Given this list of marker genes PRMT6, AFG3L2, DLD, PGK1 (phosphoglycerate kinase 1), SPCS1, CTSC, ADAMTS18, TIMP2, ASTL, ADAM2, METAP1, RBBP6, PABPN1L, ZYG11B (NCBI Gene Id 79699), KLK8, PTPN23, CELA3A, KLHL12, PRAMEF7, RNF148, KLHL42, HGS, ECSCR, PCYOX1L, USP19 (ubiquitin specific peptidase 19), USP17L11, KLHL22, CHMP2B, HINT1, TLL2, MINDY1, UFSP1, ELANE, CDC16, JMJD7, PRSS58, AMBRA1, NRIP3, SENP8, SDE2, MAGEA3, VPS36, AFG2B, UBXN6, RCHY1, ADAMDEC1, CDC27, ANKZF1, PSMB7, RC3H2, KLHDC1, PGPEP1L, CAPN11, LRRC75A, NEDD8, OPHN1, PKD1, CSTB, PTPN1, OTUD3, MAGEF1, APH1A, PGA5, GSN, CTSV, MEP1A, HIPK2, DTL, TANK (NCBI Gene Id 10010), SIAH3, AURKAIP1, UMOD, PRAMEF5, PRSS41, SIRT2, TF, PSMF1, UQCRC2, DESI1, USP18, WDR26, LONRF2, PHEX, KLHL28, PLGRKT, CPD, USP20, NFE2L2, PRPF19, FADD, CAPN13, SNF8, RSPRY1, EFNA1, CHMP1B, CASP3, MVB12A, PGA4, MAEA, CFL1, SNX33, GID8, ENC1, CDC23, FEM1B, TMUB2, ANAPC11, MPND, UBXN8, CAPN5, SOCS2, ANAPC10, TMPRSS11A, PRAMEF8, SEC61B, DCST1, STAM2, DNAJC3, DYNC2H1, CPLANE2, ASB9, CASP8, PRAMEF11, CIROP, PEPD, PRICKLE1, VHL, UBR3, CDC26, PSMA6, RNF139, ANAPC2, MTOR, GAS1, UBE2U, PRAMEF6 (PRAME family member 6), GIPC1, PSMD12, COMMD1, CBFA2T3, BAG5, FBXO22, MMP15, COPS5, PRNP, SGTA, DDI1 (DNA damage inducible 1 homolog 1), VTN, CANX, PRSS48, FAP, NTAN1, CBL, CAPN3, ANAPC13, RNF7, RNF168, USP6, SUMO2, MYSM1, IMMP1L, C1S, SPG7, UBC, RFPL1, UBXN2B, PSME3IP1, NHLRC1, MBP, DDRGK1, RCE1, BMP1, OTUD7B, CHMP1A, PTK2B, PCSK2, GAN, TNFRSF1B, SPPL2B, OVCH2 (NCBI Gene Id 341277), PRAMEF26, MMP10, PRAMEF1, UBE2L6 (NCBI Gene Id 9246), FGB, TGM2, VSIR, SPOCK2, USP46, UBA6, ATP5IF1, ADAMTS10, CPA5, CLU, MYLIP (myosin regulatory light chain interacting protein), RPL23, AGBL4, MINDY4, MINDY2, SERPINB4, RBMX, RNF19B, ACTMAP, ITCH, TAF9, PARL, OXA1L, RPL11, USPL1, SPSB3, PRSS33, HERC4, UBE2S, RNF20, DPEP3, RNF11, GPX1, MYH9, ARIH1 (NCBI Gene Id 25820), MMP1, KLHL2, KCNE2, ADAM33, ANKRD9, ADAMTS1, RAD23B, UBE2D2, TRAF4, RNF180, ASCC2, UBE2C, AGTPBP1, ERMP1, MMP28, USP17L22, USP34, PRAMEF20, CARD18, FBXL19, ISG15, NSFL1C, TP53INP2, CHMP2A, CELA2A, MMP17, TRIM58, MYC, RNPEP (NCBI Gene Id 6051), NHLRC3, USP43, PCSK1N, MARCHF7, DNAJB9, TOLLIP, SLC30A8, PSMC2, PDCD6IP, CDK5RAP3, PSMA2, GGT3P, RPGR, UBQLN4, SHH, PIGK, KLHL20, PSMB4, COPS3, MST1L, PITRM1, PROC, HECW1, HERPUD1, SNX12, RMND5B, ATP6AP2, CSNK1D, FBXO10, ECRG4, VCPIP1, PSMD3, DPEP1, EPPIN, RHBDD2, UCHL1, ADAM30, PRAMEF25, FXN, PML, NFE2L1, UBXN4, TRIB3, TBL1X, TMTC3, SERPINE2, UBA52 (NCBI Gene Id 7311), FBXO6, KAT5, USP17L20, SERPINB3, ADAMTS2 (ADAM metallopeptidase with thrombospondin type 1 motif 2), HSP90B1, SCRN3, OS9, ANAPC16, ERLIN2, PSMB11, ANAPC5, GGT1, TOR1A (NCBI Gene Id 1861), VASH2, USP15, SPRTN, UBE2I, PPP2CB, ZFAND2B, RNF126, DCAF13, CRB2, JOSD2, ZMPSTE24, USP12, USP17L13, KCTD2, USP26, OTUB1, ADAM18, FBXL15, ALAD, UBE2W, FKRP, TIMP3, TRIM45, UBXN1, FBXO31, SERPINE1, GSAP, FBXO3, ELOB, KLK7, TMEM208, TNFAIP3 (TNF alpha induced protein 3), ADAM9, RNF40, DNAJB2, ADAMTS4, LIAT1, FBXO38, FBXO44, ADAM21, FBXO4, MMP21, KLHL1 (NCBI Gene Id 57626), BLMH, PRSS42P, OTUD6B, PRAMEF17, PRAMEF12, KLK6, RHOBTB3, SMURF1, TMEM129, HERC3, TMPRSS13, EIF3F, SIRT1, FBXL2, ACE, MAN1A1, MATCAP2, PRSS29P, KLHL17, SERPINB8, ARHGAP5-AS1, GRN, COLEC10, SERPINB9, LNPEP, CSNK2A1, PRELID1, DERL3, ZNRF4, PREP (prolyl endopeptidase), FBXW4, MME, UBE2K, CFB, USP17L15 (NCBI Gene Id 124906420), HPR, FBXL20, PCSK1, SDF2L1 (stromal cell derived factor 2 like 1), UBR1, DPP7, ERO1B, ADAMTS15, PRSS51, SUMO1, CNOT4, OMA1, AGBL3, FBXL3, FBXL7, AGA, HECW2 (HECT, C2 and WW domain containing E3 ubiquitin protein ligase 2), STUB1, RNF128, PIDD1, MMP12, ESPL1, CLCA4, TSPAN15, ADAM22, CTSG, TRHDE, PTK2, UBQLN2, WDR77, CLPP, MMP7 (matrix metallopeptidase 7), PSMA3, ACR, TRAF3, TMEM259, MMP25, USP49, TINAG, USP14, F2, CUL2, USP17L18, APOH, BRSK2, IL10, OTUB2, RHBDD1, STAMBPL1, PPP1R11, USP7, FBXL18, DPEP2 (NCBI Gene Id 64174), DPP6, HGFAC, OTUD5 (NCBI Gene Id 55593), USP31, GGT2P, ADAMTS13, PRSS12, BAG6, TPP1, DHCR24, PREPL, SEC11C, TMPRSS4, GZMB, CHMP6, ADAM29, CRBN, AMN1, ATG4B, TNF, RELN, RET, PGPEP1, CELA1, DERL2, ALG13, CHMP5, USP40 (ubiquitin specific peptidase 40), HTRA1, PSMD11, TMPRSS9, KLF1 (NCBI Gene Id 8055), CARD17P, PRAMEF27, MEP1B, PRAMEF22, GID4, PRSS8, PCYOX1, KCTD17, CCAR2, ENDOU, ADAM15, ATXN3, NCSTN, TMPRSS3, TMPRSS11D, MMP26, RNF122, UBE4A, ARIH2, ADAMTS14, METAP2, APEH, ADAM10, GLI3, AXIN1, PRAMEF14, NRDC, ASB1, PSMD1, SPOCK3, UBAC2, CSTL1, FBXO21, PSME2, RHBDF1 (NCBI Gene Id 64733), DNPEP, ATXN3L, TRIB2, APPBP2, BACE2 (NCBI Gene Id 25825), MBTPS2, CDK5, MAN1B1, VASH1, CCNF, USP22 (NCBI Gene Id 79397), KLHL15, MIDN, TRIM67, HGF, USP51, TPSB2, CPA3, ERLIN1, CAPN9, PRKACB, TRIP4, PM20D1, DPP3, RNF111, BAD, CHMP4B (NCBI Gene Id 60501), CLN6, COMP, CPA4, CTSK, KLK12, PRAMEF19, MELTF, UBE2D3, PISD, FBXL22 (F-box and leucine rich repeat protein 22), TBL1XR1, MAN1A2, HDAC6, SPCS2, ADAM7, PRSS3P2, RNFT1, KLHL29, UBE2B, USP17L2, CTSH, EEF1AKMT4-ECE2 (EEF1AKMT4-ECE2 readthrough), CAPN12, SH3RF3, LONP1, NPLOC4, MMP14, USP54, HPN, ECM1, DPP4 (NCBI Gene Id 1803), IFNG, ADAM12, DESI2, ADAMTS9 (NCBI Gene Id 56999), PRAME, BFAR, NDFIP2, FBXL6, SEL1L, NR1H3 (nuclear receptor subfamily 1 group H member 3), TPSG1, UBE2L5, CPQ, XPO1, PTPN3, CHMP7, CNTN2, IDE, USP9X, DCAF11, KLK11, KLHL6 (kelch like family member 6), FBXW7, ACAN, ATP23, IFT52, VPS37B, KCMF1, CTSL, CPA6, GLMN, ANXA2, HFE, TNP2, PSMC1, IL1B, SERPINB1, LMLN, KEAP1, ENO1, MYRFL, CTSB, RNF115, C1R, NAALAD2, RNF125, KNG1, TGFB1, UBE2E1, UBQLN1, WFS1, SENP3, DPP9, PAQR3, PSMD10, ZNF598, CST3, PGA3, SPSB2, ACE2, CUL4A (cullin 4A), BCHE, UBAP1, TRIM71, RAD23A, TMPRSS11B, MALT1, CLGN, PRSS21, SEC11A, CCIN, SKP2 (S-phase kinase associated protein 2), PYHIN1, CDC20B, C2, KLK14, PRSS3, FOXRED2, SH3RF2, DNAJB12, RNF26, TMEM67, IMMP2L, RHBDL1, CPB1, KLKB1, F7, SPPL3, ECE2, CHMP4A, COLEC11, PSMA8, WDR91, F9, USP9Y, PCNP, ECEL1, MMP8, FBXO46, MMEL1, ASCC3, FGFR4, SPON1, PLAU, PSMD14, STT3B, UBE2A, USP30, APH1B, MMP9, BIRC2, TRIP12, KLHL38, CTSO, CNDP2, FAM8A1, USP11, PCBP2, RBX1, F10, OSBPL7, KLK13, RNF121, MIB1, TIMP1, RNF14, CASP5, PLK3, CAV3, TRIM28, DPP8, NEMF, UBXN11, FEM1A, PEX10, IPP, CASP14, TRIM38 (tripartite motif containing 38), PTEN, MAFB, ADAM17, PRSS55, REN, APC2, IST1, AGBL5, TSG101, S100A10, KLK15, PLK1, CAPN8, PROZ, PLA2G7, KLK4, SPSB4, KLHL41, RCN3, USP5, RFX4, TRIM31, LACTB (lactamase beta), RNF144A, PCSK4, SENP2 (SUMO specific peptidase 2), FAU, ADAM32, PRSS36, ADAMTS7, PCSK6, CALR, SPPL2C, RNF133, UBA1, CUL1, IFI27, TRIM72, RNF185, HDAC2, MKRN2, FBXL13, NEDD4, PAPPA, PRSS16, UBE2R2, XBP1, PTCH1, MIR126, FAF1, KLHL24, AMZ2, HTRA2, LRRK2, WNT10B, TPSD1, RNF130, SENP5, PACSIN3, PSMA1, SMURF2, SERPINF2, TMPRSS12, F3, MASP1, PSME4, CAPNS1, YOD1, CAPN15, RBP3, CPXM2, TMPRSS15, EDEM3, MMP20, FGG, HACE1, PCSK5, CLOCK, DTX4, XPNPEP1, ZFAND2A, SEMG2, NAGLU, YIPF5, PRAMEF4, CLPX, BCAP31, UBR2, TAF1, AKIRIN2, PDCL3, LONP2, UBE2D1, USP3, CLEC3B, WWP2, RPL5, UBAP1L, EIF3H, ERCC8, VPS37C, RNF19A, ZER1, PMPCA, TRIM32, SH3D19, MIR152, NKD2, RYBP (RING1 and YY1 binding protein), UBR4, GGT5, MTM1, ASPH, ASB2, DCAF12, PSMB1, FOLH1B, PSMD4, AGAP3, WDR81, DDIT3, ACP4, CASP6, A2ML1, CUL3, PLAUR (plasminogen activator, urokinase receptor), UBE2Z, HTRA4, SIAH2, SVIP, CDC34, FBXL16, RNF6, FAM111A, RNF103, USP21, SRC, PRSS27, KLHL3, PRAMEF9, CPVL (carboxypeptidase vitellogenic like), TMUB1, KLHL30, FZR1, TMPRSS11F, ATG4D, UBA7, FAM111B, ST14, PSEN1 (NCBI Gene Id 5663), SUFU, MTA1, TRIM39, IHH, PSMD13, SH3RF1, HABP2, OVCH1, WAC, TMPRSS6, DET1, CLN3, FBXW5, CAPN7, USP36 (NCBI Gene Id 80160), UBR7, CFD, PRAMEF15, CSNK2B, SOCS7, STAMBP, PSMC6, RUNX1, ADAM11, SOCS4, CPA1, CHAC1, DAB2IP, ATP13A2, RGMA, VPS25, F8A3, GLG1, KLHL7 (NCBI Gene Id 55975), PRSS22, SPPL2A, PRSS50, TMF1, UBXN7, SYVN1, UFD1, STYX, PM20D2, PRAMEF2, RFFL, PGC, RNF25, UBE2J2, ECE1, NR1H2, USP37, CTSD, FBXO17, PRSS53, GZMA, CDK2, L3MBTL3, SEMG1, TNP1, NPEPPS, DCD, RPS6KA2, CYFIP2, KBTBD7, CST4, MARCHF6, TRABD2A, CAPN14, PRSS38, SAYSD1, KEL, YME1L1, TMPRSS11E, LAMP3, CASP10, CDKN2A, RNF149, USP25, RNF5, CASP1, SNX9, PSEN2, PITHD1, KLHL8 (NCBI Gene Id 57563), CAV1, HUWE1, AURKA, OTULIN, SEM1, ARMC8, TRPC4AP, RECK, USP4, NCCRP1, RPS7, ZNRF1, VPS4A, ADAM19, CWH43, CPN1, TSPAN17, MMP27, TREM2, C1RL, H2BC1, USP17L1, CPB2, CELA2B, MMP11, CR1, CHMP4BP1, CTRB1, NUP98, DHH, DDA1, THOP1 (thimet oligopeptidase 1), TNFAIP1, CTSA, AQP11, CCBE1, FBXO7, FBXL14, PRAMEF13, UBE4B, PSMB10, PABIR1, PRSS45P, KDM8, KLK2, TOM1L1, THBD, XPNPEP2, AXIN2, PCSK7, VPS4B, KLHL18, IVNS1ABP, TMPRSS5, XPNPEP3, NEURL3, SCG5, NAPSA (NCBI Gene Id 9476), PHF20L1, CAPN10, KLK10, RNF123, ADRM1, KCTD6, PIK3C3, EPHA4, SVBP, TMPRSS2, CAPN6, APP, SIRT4, TRABD2B, NPEPL1, ADAMTS20, ZNF418 (zinc finger protein 418), ADAM8, ADAMTS17, KLHDC3, ANAPC1, SRGN, VPS37A, MAN1C1, PRTN3, VPS28 (NCBI Gene Id 51160), NRIP2, HSPA5, RNF8, CELA3B, PELI1, USP28, USP2, CFH, TIMP4, STOML2, KLHL23, SENP6 (SUMO specific peptidase 6), UCHL3, UBE3A, KLK1, USP17L10 (ubiquitin specific peptidase 17 like family member 10), KLHL10, TRIM2 (tripartite motif containing 2), CHFR, UBE2G1, CORIN, RPS27A, USP47, FBXL12, PIP, SCRN1 (NCBI Gene Id 9805), MIR128-1, UBE3B, CFLAR, DNAAF4, ADAMTS12 (NCBI Gene Id 81792), CTSF, TYSND1, AUP1, PRSS47P, PSMA5, TBC1D10A, ATG4C, WNT1, ELOC, LTN1, MVB12B, ADAMTS3, MYRF, PRSS23, ANKIB1, RACK1, CASP12, PSMB9, GSK3A, CASP9, ENPEP, TRIM26, COP1, RNF215, EDEM2 (ER degradation enhancing alpha-mannosidase like protein 2), CLN8, INPP5B, RC3H1, CSNK1A1, HERC6, JKAMP, PLAT, PEX12, ANAPC15, SHARPIN, UBL7, LAP3, SMARCC1, PSMD6, SENP7, N4BP1, HJV, GZMK, RNF34, BRCC3, SQSTM1, ERAP2, PSMD9, EPM2A, HM13, OTUD6A, CEBPA, FHIT, FCN2, DISP1, NPEPPSP1, CBLC, RNF10, FBXO11, SERPINB13, CMA1, RNF4, KCTD10, RNF43, PSENEN, PSMA4, UBXN2A, TMX1, SCRN2, RNF41, PSMC4, SENP1, RNF216, CTSS, LDLRAD3, FBXW2, UBA3, SPCS3, PMAIP1, RNF13, TMEM168, CTSE, PRSS57, ANPEP, TRIM21, CTRB2, F12, HSPA1B, USP17L6P, LCN1, MAPK9, RNF186, PSMD7, UBXN10, BRINP1, VPS37D, SPOP, NDFIP1, TOPORS, AZU1, IFT172, PBK, FBXO9 (NCBI Gene Id 26268), UBE2N, UBB, CACUL1, AKT1 (AKT serine/threonine kinase 1), PAPPA2, PSMB3, FOLH1, FBXO8, UFL1, TGFB1I1 (NCBI Gene Id 94988), GPLD1, UFSP2, FOXF2, QRICH2, TINAGL1, ADAM20, ROCK1, PANO1, MINDY3, DDB1, HID1, KLHL35, UBD (NCBI Gene Id 95374), PRAMEF33, KCTD21, NEDD4L, FBXW8, RNF170, FBXO27, TLL1, ARRB1, GNA12, GET4, PSMB6, CPM, BAP1, UCHL5, RHBDL3, CUL7, GCLC, KLK9, HSPA1A, FURIN, TRIM3 (tripartite motif containing 3), PINK1, DVL1, GAPDH, GABARAP, USP35, NUDT15, RNF217, TSPAN5, FGA, FBXW11, ADAMTS19 (ADAM metallopeptidase with thrombospondin type 1 motif 19), KBTBD12, DNAJC1, WWTR1, KLHL5, WWP1, SELENOS, TP53, ERLEC1, KLHL25, DTX3L, PPP2R5C, UBE2H, STAM (NCBI Gene Id 8027), USP42 (NCBI Gene Id 84132), HECTD3, TRIM13 (NCBI Gene Id 93520), RLIM, TPSAB1, BAG2, AGBL2, PRSS46P, TLK2, SEC11B, TRIM25, JOSD1, FAF2, MBOAT4, SH3BGRL, CASP2, DAB2, OTUD7A, KBTBD3, ADAM23, ADAM28 (NCBI Gene Id 27337), KLHL4, NUPR1, PRSS37, CPNE1, ATG4A, TRIM9 (tripartite motif containing 9), ZNRF2, CSNK1E, LVRN, BAK1, PSMC5 (proteasome 26S subunit, ATPase 5), P4HB, PLG, PSMA7, USP32, KY, CTRL, CUZD1, RNF146, TRIB1, SIRT6, IKBKG, NLRP7, USP44, HAMP, CASP4, SOCS5, EPG5, TRAF7, MMP3, UBL4A, DMAC2, CTRC, C2CD3, AFG1L, SLC30A5, MAP1A, USP48, CCDC47, MST1, RBCK1, HMCES, ANGPTL8, CAPN2, PRAMEF10, UBQLNL, LAPTM5, HSP90AB1, CCAR1, ADAMTS5, KBTBD8, PSMD2, GSK3B, AMFR, TPP2, PRSS1, FMR1, DERL1, ANAPC4, MMP13, IL1R2, CPXM1, ZNRF3, NLRC4, SMAD7, USP17L24, LRIG2, TM4SF20, ASB11, OLR1, LGMN, CARD16, ADGRV1, UBR5, CUL5, CAMLG, CUL9, RNF167, ARMC5, ATF6, CUL4B, EGF, FBXO39, PSMB8, USP29, LATS1, METAP1D, TTC3, ATE1, CLN5, MMP19, FCN3, KLK3, SPSB1, RNF150, TASP1, USP38, CCDC22, AOPEP, PSME1, PSMB2, ADAMTS6, UBE2G2 (NCBI Gene Id 7327), RNF175, CPE, BACE1 (NCBI Gene Id 23621), CLCA2 (NCBI Gene Id 9635), F8A1, CTSZ, PRKCQ, F8A2, MATCAP1, UBE3C, F11, USP45, HERC5, LTA4H, WFDC2 (WAP four-disulfide core domain 2), FBXO48, UHRF1, FBXL17, PSMC3, PCSK9, PCOLCE, KBTBD2, CTNNB1, ZRANB1, UBQLN3, FBXL4, DAG1, IFT80, AEBP1, IL33, BTRC, SOCS6, ARAF, PRKACA, BBS7, PSMD8, GZMM, KIF14, ZSWIM8, CNDP1, KLHL40, CTSW, CYLD, APC, OTUD1, DNAJC10, CARD8, CHMP4C, USP17L21, PRAMEF18, LTF, RHBDL2, CSNK2A2, CSTA, NAALADL1, TMEM126A, MMP24, CALR3, GZMH, NLN, USP24, KLK5, MIPEP, KCTD5, RNF213, OTUD4, USP33, PJA2, SIAH1, P2RX7, USP8, IRGQ, UBE2J1, PRKN (NCBI Gene Id 8004), AMZ1, ECPAS, RNF145, USP17L3, CDC20, USP13, MBL2, MMP2, USP27X, PARK7 (NCBI Gene Id 113880), RNF187, PRKCG, VCP, KLHL11, BMAL1, THBS1, SPINK5, HSPBP1, PRSS54, SKP1 (NCBI Gene Id 6500), MMP23B, CAPN1, PERP, ASPRV1, ARRB2, CLCA1, CASP7, ARRDC1, USP10, TBX21, KLHDC2, FBXL5, PSMB5 (proteasome 20S subunit beta 5), KCTD13, DCAF1, ARK2N (arkadia (RNF111) N-terminal like PKA signaling regulator 2N), EDEM1 (ER degradation enhancing alpha-mannosidase like protein 1), PRCP, GBA1, OGT, APOE, USP17L5, NUB1, CPA2, HECTD1, FETUB, UBE2L3, TMEM98, ADGB, USP17L12, HP, ERAP1, KBTBD6, CHMP3, GABARAPL2, LRP8, RNF144B, RNF114, ADRA2A, RNFT2, ADAMTS8, DISC1 (DISC1 scaffold protein), PARP1, PRSS56, ASRGL1, FCN1, KLHDC10, FBXO2, CPO, PSME3, SEL1L2, SCPEP1, RNPEPL1, PLAA, DDI2, PIAS1, LPA, DPP10, FBXO45 (F-box protein 45), UBE3D, RMND5A, KLHL21, NLRP1, TMPRSS7, AREL1, CPZ, TTC36, MMP16, USP17L17, MDM2, USP16, USP17L19, PRSS2, HTRA3, UBE2D4, ANAPC7, CFI, USP1, NR1D1, AGBL1, HERC2, LNX1, SPOPL, NOP53, ADAMTS16, MASP2, PMPCB, RNF166, MBTPS1, FEM1C, here is a description of the gene set: studied in species Homo sapiens The hydrolysis of proteins into smaller polypeptides and/or amino acids by cleavage of their peptide bonds. Human Gene Set: GOBP_PROTEOLYSIS